Given this list of marker genes Slc25a42, Slc25a5, Slc25a36, Gjb1, Lrrc8b, Abcc1, Lrrc8e, Slc19a1, Calhm6, Slc25a25, Shoc2, Lrrc8a, Calhm4, Lrrc8d, Lrrc8c, Gja1, Cd47, Slc17a9, Slc25a33, Slc25a41, Abcc4, Slc25a19, Slc25a32, Slc25a23, Adcy10, Calhm5, Abcc5, Abcc6, Ank, Calhm1, Slc35b2, Slc25a47, Slc35b3, Slc35b1, P2rx7, Slc46a2, Epg5, Slc25a24, Slc25a17, Calhm2, Panx1, Slc25a31, Slc25a54, Slc25a4, Calhm3, Slc25a51, here is a description of the gene set: Mouse Gene Set: GOBP_NUCLEOTIDE_TRANSPORT The directed movement of a nucleotide, any compound consisting of a nucleoside that is esterified with (ortho)phosphate, into, out of or within a cell. studied in species Mus musculus